Given this list of marker genes GRIN2B, CAMK2D, GRIN2C, CAMK2A, CAMK2G, CALM1, DLG1, GRIN1, GRIA2, DLG3, GRIN2A, NEFL, CAMK2B, DLG2, GRIA1, LRRC7, DLG4, GRIA4, ACTN2, GRIA3, GRIN2D, here is a description of the gene set: studied in species Homo sapiens At resting membrane potential, the NMDA receptor ion channel is blocked by extracellular Mg2+ ions and is unable to mediate ion permeation upon binding of ligands (glutamate, glycine, D-serine, NMDA). The voltage block is removed upon depolarization of the post-synaptic cell membrane and Mg2+ is expelled from the NMDA receptor pore (channel), resulting in activated ligand-bound NMDA receptors. The depolarization of the membrane may happen in response to activation of Ca2+ impermeable AMPA receptors, which facilitates Na+ influx, contributing to the unblocking of NMDA receptors. For review, please refer to Traynelis et al. 2010, Paoletti et al. 2013, and Iacobucci and Popescu 2017. part of: Activation of NMDA receptors and postsynaptic events Reactome Pathway: Unblocking of NMDA receptors, glutamate binding and activation